Given this list of marker genes MUC20, MUC7, MUC5AC, MUC4, MUC3A, MUC17, MUC5B, MUC19, MUC2 (NCBI Gene Id 4583), MUC15, MUC3B, MUC13, GALNT12, MUC21, MUC12, MUCL1, MUC16, MUC6, MUC1, here is a description of the gene set: Reactome Pathway: Defective GALNT12 causes CRCS1 species: Homo sapiens part of: Diseases associated with O-glycosylation of proteins The family of UDP GalNAc:polypeptide N acetylgalactosaminyltransferases (GalNAc transferases, GALNTs) carry out the addition of N acetylgalactosamine on serine, threonine or possibly tyrosine residues on a wide variety of proteins, and most commonly associated with mucins. This reaction takes place in the Golgi apparatus. There are 20 known members of the GALNT family, 15 of which have been characterised and 5 candidate members which are thought to belong to this family based on sequence similarity. The GALNT-family is classified as belonging to CAZy family GT27. Defects in one of the GALNT family, GALNT12 (MIM: 610290) can result in decreased glycosylation of mucins, mainly expressed in the digestive organs such as the stomach, small intestine and colon, and may play a role in colorectal cancer 1 (CRCS1; MIM:608812). CRCS1 is a complex disease characterised by malignant lesions arising from the inner walls of the colon and rectum.